Given this list of marker genes ST6GAL1, HIRIP3, COQ4, LYRM4, KLRB1, TMEM79, SARDH, ARL2BP (NCBI Gene Id 23568), POLR3E, MYO9B, COPS8, ARPP19, NECAB3, IL23A, TBC1D1, THBD, TSPAN3, TRMT10C, CEP76 (centrosomal protein 76), HK2, POLR1D, G0S2, MIF, WDR83OS, COQ9, NDUFB3, KIF11, IRAK1, SH2B1, PHB1, MAP3K11, FCHO1, MRPS12, NOD2 (NCBI Gene Id 8135), ARMC6, TARBP2, POLD1, MIR3945HG, PPARGC1B, BBS1 (NCBI Gene Id 79702), ATP5PF, SLC25A3, NEK9, UQCC1, PARL, TBRG4, TOMM70, ZNF146, VAMP5, UBE3C, RNF40, FASTKD1, ELAVL1, FAM234A, BCL9L, NUDT4, ABHD8, DNAJC11, FAM162A, TAF1D, MIR646HG, PARP10, C15orf48, POLL, BTF3, MRPS24, LDHB, TDRD10, TUFM, HDHD5, DENND5A, CCDC51, DHPS, ERI1, GTF3C4, TECPR1, TPI1, LIAS, GART, RNF5, SFXN4, C10orf67, C17orf75, NFKBIA, MRPS33, RANBP10, WDR13, INTS6L, TARS1, RAB38, ZNF768, ATP5PB, MAEA, MPRIP, COX10, PLOD2, RPS15, SPATA16, TMEM268 (NCBI Gene Id 203197), SLC4A7, C19orf53, ZNF438, TPCN1, SDHB, MRPL12, GOLGA7, BRD7, CARS2, THEM6, TMEM201, CHCHD10, POLR3B, CDK5RAP1, FBP1, CUTC, RAB28, RSAD1, ITGB8, KIAA0586, EIF3K, INTS15, COG2, SAMM50, MRPS21, MDH2 (NCBI Gene Id 4191), PHF10, XPOT, NDUFV1, SEMA4B, MAPKAPK2, LPGAT1, EIF3D, CCT7, FAF1, THEMIS2, FKBP15, NDC1, STEAP3, TWNK, CPXM1, SLC31A1, RPL38, MTLN, GATB, WDR7, SLC35A4, TMC6, GLRX5, GTF3A, BCO2, RRS1, KAT6B, TRIM56, FAIM2 (NCBI Gene Id 26294), NDUFB5, FAM86B1, C6orf136, AKT1S1, DNAAF5, KLHL5, LGALS9, DMAP1, SRSF8, UQCR10, MRPL35, ATP5F1A, ALKBH7, HNRNPC, ST3GAL1, CCDC88C, ARHGAP22, DDX21, COQ3, AFG3L2, FAM120C, EIF2B3, MRPS7, EPRS1 (NCBI Gene Id 2058), MGA, AIFM1, IFRD2, GPR84, COQ5, LTA4H, PRKAA1, ZBTB7A, ERLIN1, CAMP, RPL32, SERPINB6, TPM1, LMTK2, SUV39H1, KAT2A, TMCO6, SLC25A12, PPP4R3B, EIF2D, EXTL3, here is a description of the gene set: species: Homo sapiens Mouse lung CD11c+ dendritic cells are composed of 2 major DC subsets, the CD103+CD11b-low/intermediate DC (CD103+ DC) and the CD11b-highCD103- DC (CD11b-high DC). These 2 subsets are functionally distinct. Comparison of their functions showed CD103+ DC Microarray analysis was performed to compare the gene expression profiles of the 2 lung DC subsets in naïve mice. from publication Edelson BT, KC W, Juang R, Kohyama M, Benoit LA, Klekotka PA, Moon C, Albring JC, Ise W, Michael DG, Bhattacharya D, Stappenbeck TS, Holtzman MJ, Sung SS, Murphy TL, Hildner K, Murphy KM (PMID 20351058) Genes down-regulated in lungh dendritic cell: CD103+ versus CD11b high. Human Gene Set: GSE17322_CD103_POS_VS_CD11B_HIGH_LUNG_DC_DN